The following is a description of a gene set: Human Gene Set: MIR5189_3P Genes predicted to be targets of miRBase v22 microRNA hsa-miR-5189-3p in miRDB v6.0 with MirTarget v4 prediction scores > 80 (high confidence targets). studied in species Homo sapiens from publication Chen Y, Wang X (PMID 31504780), and this is the list of marker genes: DIP2C, MTMR6, TP53INP2, C3orf62, PTPRJ, SLC18A2, CRYZ, ZNF827, C1orf21, FRAS1, SECISBP2L, CLEC12A (NCBI Gene Id 160364), MSI2, UGT8, CNBP, NUDT11, CBFB, NDUFS4, ITGA4, EFNB3, HGF, TMEM38A, RNF41, XPR1, SLC12A5, ARMC8 (armadillo repeat containing 8), FAM117B, PSMC3IP, PBX1, PPM1B, DSEL, CTNNA2, TSTD2, ANTXR1, ITPRID2, FCER1G, TGIF2, UBR5, EIF5A2, YARS1, EIF5AL1, KPNA3, RIN2, MSTN, ADORA2A, SELENOS, ORAI3, LCE2C, ZNF488, RAB6B, PRRT4, PTPN4, PRKDC, JAG1, STX4, ITPR1 (NCBI Gene Id 619543)